Given this list of marker genes Fgf17, Fgf9, Fgf2, Fgf18, Fgf1, Fgf8, Fgf20, Fgf5, Fgfr3, Fgf23, Fgf16, Fgf4, Galnt3, here is a description of the gene set: FGFR3 ligand binding and activation Mouse Gene Set: REACTOME_FGFR3_LIGAND_BINDING_AND_ACTIVATION species: Mus musculus